The following is a description of a gene set: Human Gene Set: GOCC_COMMITMENT_COMPLEX A spliceosomal complex that is formed by association of the U1 snRNP with the 5' splice site of an unspliced intron in an RNA transcript. studied in species Homo sapiens, and this is the list of marker genes: PRPF39, SNRPD1, SNRPC, U2AF2, SNRPD3